The following is a description of a gene set: Human Gene Set: REACTOME_RNA_POLYMERASE_III_TRANSCRIPTION_TERMINATION RNA Polymerase III Transcription Termination species: Homo sapiens, and this is the list of marker genes: POLR2H, NFIA, NFIX, POLR2L, NFIC (NCBI Gene Id 4782), POLR3F, POLR3K, POLR3H, POLR1C, POLR3D, POLR3B, CRCP, POLR2E, POLR3GL, POLR3E, POLR1D, POLR2F, SSB, POLR3A, POLR3G, POLR3C, POLR2K, NFIB